Given this list of marker genes CD274, PDCD1LG2, PIK3R3, PTPN6, PTPN11, PDCD1, PIK3CD, PIK3R1, PIK3R2, here is a description of the gene set: studied in species Homo sapiens Pathway Definition from KEGG: (PDL1,PDL2) -> PDCD1 -> SHP1/2 -| PI3Kdelta Human Gene Set: KEGG_MEDICUS_REFERENCE_PDL_PD1_SHP_PI3K_SIGNALING_PATHWAY PDL/PD1-SHP-PI3K signaling pathway. Pathway ID: N01165. Pathway type: Reference. Pathway class: nt06530 PI3K signaling.